Given this list of marker genes FGF2, GATA5, SPRY1, CTNNB1, FGF10, ROBO1, HOXC11, FGF8, ROBO2, FGFR1, WNT2, POU5F1, MESP1, AR, HOXA11, FRS2, DKK1 (NCBI Gene Id 22943), SIX1 (SIX homeobox 1), WNT2B, GDNF (NCBI Gene Id 2668), BMP2, BMP4, FGF1, here is a description of the gene set: species: Homo sapiens The interaction of two or more cells or tissues that causes them to change their fates and specify the development of an organ. Human Gene Set: GOBP_ORGAN_INDUCTION